Given this list of marker genes GLIPR2, TGFBR1, VPS13C, DNAJB9, IL16, SLCO3A1, GBP5, CHDH, HAUS3, DYNLT3, ICAM2, BIRC3, ATP6V0B, LINC01783, HNRNPDL, DAG1, IFNGR2, PAM16, CLUHP3, ESPN, KANSL3, CYTH1, RAB18, PCSK7, MYBL1, SERPINI1, SGK3, GOLGA7B, ANK3, GARRE1, LINC00528, AHR, MAFG, TMEM200A, THAP7-AS1, FAS, IL10RA, CLN5, PCYOX1, SELENOK, DNAJC3, ZNF134, UPP1, CDC14A, AHSA1, CPOX, TRIM26, SOS1, HSPA1A, KLK8, SLC26A11, SCARNA17, BCL2, ZNF329, ILF3-DT, PPP1R12A, DMD, BLVRA, LINC02481, ZBP1, LINC00615 (NCBI Gene Id 442759), DLEC1, ITGA6, ATG14, ARHGEF12, RTKN2, DANCR, APOL6, ABHD13, G3BP2, MAGT1, ATP13A1, NFKBIZ, SEMA4C, RIMKLB, HBEGF, CISH, GLYR1, TMBIM1, TDRD7, CXCR4, LPAR6, TIGIT, LY9, PLEKHB2, ACVR1C, IVNS1ABP, HDAC9, FKBP4, TNFRSF10D, PXN, KLF2, ARRDC3, GSR, NDRG1, TRAM1, SH2D3A, ABHD11, GJB6, PDLIM5, WASHC4, GUK1, HACD4, IL15RA, ITGB1, CCR6, SYNE2, RPS6KA5, SQSTM1, N4BP2L2, HMOX2, PDLIM2, CD99, WWP1, TPBG, UXS1, IL6R, SNX30, ITGB7, KIAA0040, NIPA1 (NIPA magnesium transporter 1), AP1S2, DNAJC6, CCDC93, HS6ST1, ZNF267 (NCBI Gene Id 9428), TXN, CDC42EP3, RSBN1, CAPN2, UBC, ABCC5, L3HYPDH, IL17RB, SPEN, STK10, TNFSF14, CYSTM1, SMPD3, MAEA, ETV7 (ETS variant transcription factor 7), PPP2R2B, LINC00639, SYNJ2BP, GPRASP1, SMAGP, CROT, PTGER2 (NCBI Gene Id 63381), CASP4LP, PLXNA4, NAP1L2, ZNF274, KAT2B, TMEM63A (NCBI Gene Id 9725), ZCCHC18, SELP, UHMK1, CYTH3, FAR2 (fatty acyl-CoA reductase 2), ST3GAL5, RETNLB, FLT3LG, FTL, CDKN2B, WDR19, IDS, TALDO1, TAB2, MEGF6, FAM13A, AFDN, FNDC3B, CYLD, EML4, TNFRSF10A, HLA-DRB1, F2RL1, PANX1, CASP1, PTPN4 (NCBI Gene Id 5775), ZC3H12A, ACAP3, MARCHF8, TENT5A (NCBI Gene Id 55603), ANXA1, IRS2, ALOX5, LYRM1 (LYR motif containing 1), OPTN (NCBI Gene Id 337928), NR3C2, RCBTB2, SOCS2, VPS35, PREPL, NEFL, TLR1, DDX60L, SBF2, here is a description of the gene set: Genes down-regulated in comparison of directly activated CD4 T cells versus bystander activated CD4 T cells. There is much evidence that T cells may be activated via mechanisms which act independently of direct TCR ligation. Despite this, the question of whether such forms of ‘bystander’ T cell activation occur during immune responses is hotly debated. To address some outstanding questions, we set up an in vitro system within which to analyse bystander T cell activation in human T cells, in the absence of the possibility for TCR cross-reactivity. In addition, we have investigated the genetic, phenotypic, and functional characteristics of bystander activated T cells. Here, we show that bystander T cell activation is, indeed, observed during a specific immune response, and that it occurs preferentially amongst CD4+ memory T cells. Furthermore, bystander activated T cells display a distinct gene expression profile. The mechanism for bystander T cell activation involves soluble factors, and the outcome is an elevated level of apoptosis. This may provide an explanation for the attrition of T cell memory pools of heterologous specificity during immune responses to pathogens such as viruses. studied in species Homo sapiens Human Gene Set: GSE13738_TCR_VS_BYSTANDER_ACTIVATED_CD4_TCELL_DN from publication Bangs SC, Baban D, Cattan HJ, Li CK, McMichael AJ, Xu XN (PMID 19201849)